Given this list of marker genes MRM2, CA5A, MT-ND6, ATP5F1A, MT-ND3 (NCBI Gene Id 4537), MT-ATP6, NAGS (NCBI Gene Id 162417), MT-ND1, PCK1, MT-TK, MT-ND4, MT-TW, MT-TV, OTC, MT-ND2, CPS1, MT-ND5, ALDH18A1, MT-TL1, here is a description of the gene set: A decreased concentration of citrulline in the blood. Human Gene Set: HP_LOW_PLASMA_CITRULLINE species: Homo sapiens Low plasma citrulline